The following is a description of a gene set: Checkpoint pathways help cells maintain genomic integrity, delaying cell cycle progression in response to various risks of fidelity, such as genotoxic stresses, compromised DNA replication, and impaired spindle control. Cancer cells frequently exhibit genomic instability, and recent studies showed that checkpoint pathways are likely to serve as a tumor-suppressive barrier in vivo. The cell cycle-promoting phosphatase CDC25A is an activator of cyclin-dependent kinases and one of the downstream targets for the CHK1-mediated checkpoint pathway. Whereas CDC25A overexpression is observed in various human cancer tissues, it has not been determined whether deregulated CDC25A expression triggers or promotes tumorigenesis in vivo. Here, we show that transgenic expression of CDC25A cooperates markedly with oncogenic ras or neu in murine mammary tumorigenesis. MMTV-CDC25A transgenic mice exhibit alveolar hyperplasia in the mammary tissue but do not develop spontaneous mammary tumors. The MMTV-CDC25A transgene markedly shortens latency of tumorigenesis in MMTV-ras mice. The MMTV-CDC25A transgene also accelerates tumor growth in MMTV-neu mice with apparent cell cycle miscoordination. CDC25A-overexpressing tumors, which invade more aggressively, exhibit various chromosomal aberrations on fragile regions, including the mouse counterpart of human 1p31-36, according to array-based comparative genomic hybridization and karyotyping. The chromosomal aberrations account for substantial changes in gene expression profile rendered by transgenic expression of CDC25A, including down-regulation of Trp73. These data indicate that deregulated control of cellular CDC25A levels leads to in vivo genomic instability, which cooperates with the neu-ras oncogenic pathway in mammary tumorigenesis. studied in species Mus musculus Up-regulated genes in breast tumors from transgenic mice overexpressing ERBB2 and CDC25A compared to those from mice overexpressing ERBB2 only. Human Gene Set: RAY_TUMORIGENESIS_BY_ERBB2_CDC25A_UP from publication Ray D, Terao Y, Fuhrken PG, Ma ZQ, DeMayo FJ, Christov K, Heerema NA, Franks R, Tsai SY, Papoutsakis ET, Kiyokawa H (PMID 17283130), and this is the list of marker genes: PROP1, ABCA3, ARHGAP19, CTSC, GALR3, LRRC71, PKDCC, RBP1, NUP42, RHOG, RCOR1 (REST corepressor 1), MKI67, SYCE2, DCAF12L1, RBP7, GMNN, OR2AG2 (olfactory receptor family 2 subfamily AG member 2), TNRC6B (NCBI Gene Id 23112), NABP1, NID2, CORO2B, C2, CCNB2, HINT1, SYCN, GLYCAM1, CREB5 (NCBI Gene Id 9586), FAM162A, A2M, TPST2, NHLH1, GTSF1, KRTAP6-1, PLA2G2E, CABCOCO1, RARG, OR7G2, RAB4B, DLGAP5, SCD, RNF128, ICOS, TNFRSF10B, OR13C8 (NCBI Gene Id 81376), ABHD3, ABCA2, GSTO1, PERM1, NKAIN3, ERMARD, TNFSF13 (NCBI Gene Id 8741), CELSR2, RNASE1, INPP5D, B3GNTL1 (NCBI Gene Id 359818), SIX1, EDEM1, HELLS, MGARP, DTX1, ECT2, ARHGEF28 (Rho guanine nucleotide exchange factor 28), AKNAD1, SLC15A1, PIP4P1, DMTN, CREB3L4, WNT10A, PLSCR1, OSBPL1A, KHDRBS3, CLCA3P, PLAGL2, OR4C15, TANC2, ARF3, ITIH5, APOM, FDX1, SPESP1, TPRA1, ARHGEF17, AMDHD2, CENPK, MRPL35, PPM1A, MKLN1, CDC26, MIA, KIF20A, AQP8, NCOA3, TM7SF2 (transmembrane 7 superfamily member 2), ANKRD2, TRPV4, FKRP, RRAGD, ADAM19, CENPA, EFHC1, PRPF4, EXOSC7, CAAP1, CUX1, ZBTB45, HNRNPA2B1, ID1, KRTDAP, VPREB3, DNASE2, GRM5, ALOX5AP, CFAP251, WSCD1, SYBU, GNMT, CDHR5, OR2J1, PRIM1, SLC5A8, PPP2R5E, NAT8, SLIT2, SRSF4, ACVR1, HS3ST3A1, FAIM2, BRCA2, LDAF1, TCEAL3, PROK1, JPT2, VWC2, RPL11, ILF2, TRIM45, TNPO3, CHIA, OR52E2, MATN2, NEK1, LRRC28, CD36, ELF4, OR1F12P, DEFB106A, CCN5, TMCO5A, ATP1B2, CD200, PLA2G2C, CKS1B, ODAPH, MED23, CCSER2, TSPO2, TMIGD3, ST8SIA6, ICA1L, MFSD13B, CPT1B, ST6GALNAC2, OR1P1, UPK1A, BIRC7, P2RY2, MYG1, CHD3, LCE1B, TSPAN17, C18orf54, EMB, CHRNA10 (NCBI Gene Id 57053), GGA3, SPATA19, SPDEF, KIF22, DTL, PGLYRP1, ANGPT2, VN1R17P, NCAM1, ALDH1A3, OR4C6, ZBED5, GLIPR1, MCM7, CCND2, SEMA3D, KREMEN1, ATP11B, SLC39A8, SHCBP1, SNHG11, C14orf132, NBEA, MAPK6, APOO, RPL22L1, PTK2B, ATF6, NFIA, CIP2A, HS3ST3B1